The following is a description of a gene set: Mouse Gene Set: REACTOME_RHOA_GTPASE_CYCLE species: Mus musculus RHOA GTPase cycle, and this is the list of marker genes: Vamp3, Acbd5, Scfd1, Iqgap3, Rtkn, Anln, Arhgap29, Tmem87a, Prex1, Myo9a, Mcam, Jup (NCBI Gene Id 16480), Pkn2, Ngef, Cavin1, Pik3r2, Arhgef10l, Arhgef28, Bcap31, Aaas, Arhgap10, Pgrmc2, Actc1, Arap2, Def6, Akap13, Daam1, Vapb, Snap23, Kalrn, Arhgap31 (NCBI Gene Id 80655), Rock1, Racgap1, Arhgap24, Plekhg3 (pleckstrin homology domain containing, family G (with RhoGef domain) member 3), Arhgap45, Arhgap39, Arhgef11, Arhgap20 (NCBI Gene Id 76232), Vav2, Arhgef7, Ktn1, Arhgef15, Dock2, Arhgef2, Rock2, Abcd3, Pkn3, Rhpn1, Arhgap28, Stbd1, Arhgef3, Arhgap19, Arhgap32, Bcr, Rasgrf2, Arhgap18, Vangl1, Plekhg6, Arhgap26, Fam13a, Pik3r1, Prex2, Mcf2l, C1qbp, Arhgef19, Arhgdib, Arhgef25 (Rho guanine nucleotide exchange factor 25), Gmip, Tagap, Tjp2, Depdc1b, Arhgap44, Arhgap8, Sowahc, Lman1, Atp6ap1, Slk, Iqgap1, Diaph3, Arhgap42, Net1, Arhgap1, Arhgap4, Myo9b, Ccdc115, Lbr, Flot1, Ect2, Arhgap6, Pcdh7, Hmox2, Arhgef12, Maco1, Stx5a, Stk10, Arhgap30, Rhoa, Obscn, Abr, Vav1, Tex2, Pkn1, Arhgap9 (Rho GTPase activating protein 9), Ophn1, Ddrgk1, Emc3, Arap1, Srgap1, Vav3, Arhgef17, Erbin, Arhgap22, Faf2, Plekhg5, Arhgap21, Ykt6, Dlc1, Arhgef18, Stard8, Arhgef1, Arhgef5, Rhpn2, Fmnl3, Flot2, Arap3, Arhgap23, Diaph1, Arhgap40 (NCBI Gene Id 545481), Mcf2, Arhgap35, Arhgef10, Trio, Arhgdia, Arhgap5, Tfrc (NCBI Gene Id 76361), Stom, Arhgap11a, Farp1, Stard13, Cav1